Given this list of marker genes IFRD2, CIBAR1-DT, FOXO3, APLP2, HLA-F-AS1, TTI2, TSPAN3, COL7A1, ST3GAL5, IFT46, HDX, SLC37A2, MYC, CYB5R2, VAV1, RCC1, HSPA9, CHN2, SRSF1, CSTPP1, SNORD89, SLC43A3, MPDU1, RAB13, BTN3A2, HYPK, INTS10 (NCBI Gene Id 55174), OXNAD1, GPHN (NCBI Gene Id 57566), SERPINB1, MCAT, GABARAPL1, FCGR1BP, GEMIN6, TMEM156, PRRG2, PTGR1, POLR1C, FAIM, CHCHD4 (NCBI Gene Id 152281), ARFIP2, FCGR3B, SCOC, WDR12, WDR46, RNASEH1, ZXDB, TRBV7-3, PPARD, PARVG, NSMCE1, CCL7, KMT5C, PDCD4-AS1, NDUFA9, PHC1, POMGNT1, MLF2, MAIP1, SWSAP1, GK5, TRMT44 (NCBI Gene Id 80015), TXNRD1, MRPL23, CHAF1A, ALKBH2, CNST, NDUFA3, KLHL5, RPL24, PDSS1, XPR1, BTF3L4, SPNS1, NEUROD6, NUDT6, NDUFB1, TGM2, CD248, NOTCH4, TWNK, OAF, RPS27A, JUNB, F8 (coagulation factor VIII), RGS3, TGIF2, FJX1, FASTKD2, PEX7, EMC7, RPL29, HIPK2, M1AP, LHFPL6, EIF3I, SUCLG1, PFDN1, SPTBN1, TUFM, ADM, SUCLG2, SHE, MRPL42, MRPL21, MYDGF, RTL6, EPHB4, SLC28A3 (NCBI Gene Id 64078), MRPL12, FHAD1, LAGE3, EFL1, SDHB, COX5A, SLC2A3, IL17RA, RPS12, KXD1, SLC49A3, IFT22, NDUFS1, RPUSD1, HMGN2P46, UCK2, ZMIZ1-AS1, DMAC1, SLC2A1, FXYD1, GCNT3, TTC8, SIL1, GART, RPL22L1, NDUFAF2, POLB, NEXN, MAPK1, PFKFB4, AIM2, SEMA4G, ENTPD7, LRP12, MAGED1, MRPL2, SCN5A, GTF3C2, FGR, XPOT, SNHG16, TSC22D1, LINC00968, SLC4A7, STEAP3, COL8A2, CHST15, SYT11, RUVBL1, DBH-AS1, COX7A2L, ZNF703, NOD2, CLDN14, HOXD9, UGT2B17 (NCBI Gene Id 7367), ALG3, DNAJC24, PLEKHA7 (pleckstrin homology domain containing A7), SLC7A8, RIDA, ZDHHC9, CR1 (NCBI Gene Id 1378), SLIRP, PDP2, MRPL24, AK3, KCNC1, SLITRK4, WDR13, CD48 (NCBI Gene Id 962), CLMN, NDUFB9, RARS1, ACADVL, ZNF683, SLC36A4, ZNF219, NELFE, COG2, MITF, RAB34, AARS1, NAXE, CD82, SSX2IP, TSFM (Ts translation elongation factor, mitochondrial), CLEC11A, TSTD2, here is a description of the gene set: from publication Gleissner CA, Shaked I, Little KM, Ley K (PMID 20335529) Genes up-regulated in monocyte derived macrophages: CSF1 versus PF4. studied in species Homo sapiens Human Gene Set: GSE20484_MCSG_VS_CXCL4_MONOCYTE_DERIVED_MACROPHAGE_UP Human blood monocytes were differentiated over six days with either 100 ng/ml M-CSF or 1 umol/l CXCL4 In atherosclerotic arteries, blood monocytes differentiate to macrophages in the presence of growth factors like macrophage colony-stimulation factor (MCSF) and chemokines like platelet factor 4 (CXCL4). To compare the gene expression signature of CXCL4-induced macrophages with MCSF-induced macrophages or macrophages polarized with IFN-γ/LPS (M1) or IL-4 (M2), we cultured primary human peripheral blood monocytes for six days. mRNA expression was measured by Affymetrix gene chips and differences were analyzed by Local Pooled Error test, Profile of Complex Functionality and Gene Set Enrichment Analysis. genes were differentially expressed between MCSF- and CXCL4-induced macrophages, 206 of them overexpressed in CXCL4 macrophages coding for genes implicated in the inflammatory/immune response, antigen processing/presentation, and lipid metabolism. CXCL4-induced macrophages overexpressed some M1 and M2 genes and the corresponding cytokines at the protein level, however, their transcriptome clustered with neither M1 nor M2 transcriptomes. They almost completely lost the ability to phagocytose zymosan beads. Genes linked to atherosclerosis were not consistently up- or downregulated. Scavenger receptors showed lower and cholesterol efflux transporters higher expression in CXCL4- than MCSF-induced macrophages, resulting in lower LDL content. We conclude that CXCL4 induces a unique macrophage transcriptome distinct from known macrophage types, defining a new macrophage differentiation that we propose to call M4.